The following is a description of a gene set: Genes down-regulated upon CSF1 treatment: monocytes (3 days) versus macrophages (7 days). studied in species Homo sapiens from publication Martinez FO, Gordon S, Locati M, Mantovani A (PMID 17082649) Human Gene Set: GSE5099_DAY3_VS_DAY7_MCSF_TREATED_MACROPHAGE_DN Monocytes mature tom acrophages in the presence of the lineage determining cytokine M-CSF. They can be further polarized into M1 or M2 macrophages with distinct functional properties. We used microarrays to detail the global programme of gene expression underlying macrophage maturation and polarization and identified distinct classes of up-regulated genes during this process., and this is the list of marker genes: PIK3C2B, PHF6, SPDYE1, PODNL1, SNRPN, UBE2J1, QNG1, TMX1, PSORS1C2, LEF1, GLIPR1L1, HNRNPH3, SEM1, GLI4, ASS1, CA10, RAB6A, CBX5, FBXL14, DIPK2B, CELF1, TMEM221, H2BC8, MSRB3 (methionine sulfoxide reductase B3), USP9Y, PCDH11Y, PALLD, FDPSP2, ABI2, PLN, TMEM176A, KLHL24, MARCHF7, FCER2, YWHAQ (tyrosine 3-monooxygenase/tryptophan 5-monooxygenase activation protein theta), PCDHB3, GALNT2, DST, CYTH2, PKN2, MYL4, EIF4E, KIF12, TPH1, TNRC6C, MDM4, TRAT1, TARP, DTYMK, PDZD9, KCNB2, INHBA-AS1, CYP2F1, EPPIN, TCF7, SGO1, TXLNGY, MALAT1, PDCD6, CORO1C, ATF2, LINC02593 (NCBI Gene Id 284598), SAT1, ANKRD20A11P, SGCD, PPP2R1B, HMGB3, HNRNPA2B1, ARID1A (AT-rich interaction domain 1A), CENPJ, HNMT, DAZAP2, BCL11B, KCNJ13, NT5M, UBASH3B, R3HDM2, CRYBB2P1, DOCK1, NLN, OSBPL5, CLPTM1L, SYCE1, CEP43, CYSLTR2, ECT2, SP4, TLE4, CALM2, ARID1B, RASGRF1, GUSBP14, PRICKLE1, GSTT4, HEXD, SON, SLC22A7, RHBDF1, TFF3, SMPD3, MYOM3, MARCKSL1, ISOC1, CMAHP, ZNF366, RARRES2, HNRNPC, ACSM5 (acyl-CoA synthetase medium chain family member 5), HOXA10, SERPINB13 (NCBI Gene Id 54735), CDY1, PRKD3, GNA13, MRPL51, PDE8B, UBE2CP4, SUB1, DNAJB6, HNRNPH1, FAAP100, CNOT6L, SP3, ATP2A2, IFT25, PAPOLG, H2AC25 (H2A clustered histone 25), KRTAP5-2, TM6SF1, PRKY, HOXA9, PHF8, CUL3, CLDN19, NIN, DES, PLEKHS1, ZBTB44, MCM8, UCN3 (urocortin 3), EXOSC6, ZNF257, MORF4L1, SRY, CD79B, TPI1, RFX3, FUBP1, CD84, SYNM, RUFY3, PAX9, INHBC, RUBCNL, PTTG3P, EVC (NCBI Gene Id 7886), TMEM212, GATAD2B, SLC22A3, HCRT, LRRN1, CDK6, SFPQ, CAPSL, INSIG1, SYPL2, PPM1D, GALNT7 (NCBI Gene Id 51809), NCAPH, LYRM2, CHRNA3, THBS1, IP6K3, ZP1, ANAPC16, SNX21, LMO2, MSI2, TMEM182, KLHDC9, ADGRB2, DDX3Y, KDM5D, ERGIC1, ZC3H7B